Given this list of marker genes CAMTA1, PLEKHF2, ZNF34, HSPA1L, BRWD1, SMNDC1, NLRX1, DLGAP1, ZNF587, ARID3A, IGFBP1, KCNJ14, TPST1, ANXA1, CPEB3, ITIH4, CLIP3, CCL23, NBR1, PTPRE, CERNA1, UGT8, MCOLN3, SYT1, DBT, KIAA0232, CNR2, SLC25A42, DDX6, SIGLEC5, FRAT2, KRT5, ZNF721, ZZEF1, PDZK1, TRIM33, GDPD3, SVIL, TM2D3, TNFSF13, TMEM143, ZNF75D, LAMP2, WDR37, HLA-DPB1, FUCA1, EFR3B (NCBI Gene Id 22979), PITPNM3, TBC1D5, BMX, MMP2, CYB5R4, HCP5, TGFA, CD55, C1orf115 (NCBI Gene Id 79762), CACNA1G, VCL, C5AR2, CES3, NAV3, CLK1 (CDC like kinase 1), HTR2A, DUS2, GIT2, BCL2A1, POMZP3, AXIN1, SYNE2 (spectrin repeat containing nuclear envelope protein 2), ELOVL5, TSGA10, SMPD3, PTGES, FCGBP, PSEN1, PPFIBP2, PLCH2 (phospholipase C eta 2), LITAF, C11orf71, GSAP, ALOX15, HK3, MUC5AC, MEF2A (myocyte enhancer factor 2A), BLK, C1D, ARRB1, PTEN, H1-4, KIT (NCBI Gene Id 5086), IGFBP3, NFE2L2, TSC22D3, OMG, REG1B, GABRR1, RABGEF1, ZSCAN32, HARS2, SYCP1, HCAR3, PPP1R12A, FBP2, MARCHF7, CPA4, ANGPT2, CYSLTR2, GPR27, NMI (N-myc and STAT interactor), USP19, PECAM1, MTHFR, RRP12, YY1, CHP1, RAB33B, FGD6, UBOX5, ZFAND5, SLC25A21, INPP5B, PNRC2 (NCBI Gene Id 55629), CBX2, COL8A1 (collagen type VIII alpha 1 chain), RAB6A, AP1G1, CYSLTR1, CALM1, SERP1, CNN2, LRRFIP1, KL, ZDHHC17, MX2, HOXC13, LAPTM4A, RIN3, TBXAS1, UBA3, PCDHGA10, MYO9B, HLA-DRB1, NADK, HLA-F, KANSL1L, CLOCK, EIF1, RHOBTB3, PRR7, CPN1, MYH4, RREB1, CD44, NSUN6, SMAD5-AS1, TXNRD1 (thioredoxin reductase 1), VAV3, CD63, LPIN1 (lipin 1), INPP4A, IGF2-AS, MID1, TXLNG, BTG1, SHC3, PARP8 (poly(ADP-ribose) polymerase family member 8), MAML1, RHEB, CHST15, YIF1B, CREG1, LONP2, MYD88, ZCCHC14, BIRC2, HLA-DRA, SLC36A1, TUB, C1RL, PPM1F, MAST1, PBXIP1, GRB10, MAST3, SOX21, TRIB1, PTAFR, IL1RAPL2, SEC62, PACSIN2, PLXNC1, GCNT2, AVPR1A, ZNF835, PCNX2, here is a description of the gene set: Genes up-regulated in comparison of eosinophils versus Th2 cells. studied in species Homo sapiens from publication Jeffrey KL, Brummer T, Rolph MS, Liu SM, Callejas NA, Grumont RJ, Gillieron C, Mackay F, Grey S, Camps M, Rommel C, Gerondakis SD, Mackay CR (PMID 16474395) Human Gene Set: GSE3982_EOSINOPHIL_VS_TH2_UP In the present study we used Affymetrix oligonucleotide microarrays to produce gene transcription profiles for the major leukocyte types in humans. This comprehensive dataset enabled us to not only establish which genes were expressed in each leukocyte type, but also which genes were expressed in each subset after activation. The used of a comprehensive dataset of gene profiles from all the major human leukocyte subsets enabled a novel and powerful means for identification of genes associated with single leukocyte subsets, or different immune paradigms.